Given this list of marker genes Fgfr1, Gnas, Cyp27b1, Vdr, Fgfr4 (NCBI Gene Id 212063), here is a description of the gene set: Any process that modulates the frequency, rate or extent of parathyroid hormone secretion. Mouse Gene Set: GOBP_REGULATION_OF_PARATHYROID_HORMONE_SECRETION studied in species Mus musculus